The following is a description of a gene set: IL-10 or IL-6 stimulation of control 129xC57BL/6 murine bone marrow derived macrophages in the presence of LPS. We used microarrays to detail the global programme of gene expression changes in response to IL-6 or IL-10 stimulation in the presence of lipopolysaccharide. BMDMs were isolated from control, IL-6-/-, and IL-10-/- mice on a 129XBL/6 mixed background mice and differentiated in the presence of CSF-1 for 6-7 days. Cells were scraped and plated in 6 well plates at 2x10e6/well. Cells were washed with complete DMEM and rested for 1-2 hr before stimulation with combinations of IL-10 (10 ng/ml), IL-6 (2 ng/ml) or LPS (100 ng/ml) for 45 min or 180 mins. Complete biological replicates were performed. Human Gene Set: GSE5589_WT_VS_IL6_KO_LPS_AND_IL10_STIM_MACROPHAGE_180MIN_UP from publication El Kasmi KC, Holst J, Coffre M, Mielke L, de Pauw A, Lhocine N, Smith AM, Rutschman R, Kaushal D, Shen Y, Suda T, Donnelly RP, Myers MG Jr, Alexander W, Vignali DA, Watowich SS, Ernst M, Hilton DJ, Murray PJ (PMID 17114459) species: Homo sapiens Genes up-regulated in bone marrow-derived macrophages at 180 min of stimulation with IL10 and LPS: wildtype versus IL6 knockout., and this is the list of marker genes: DAZAP1, RSPO3, GTF2H4, NBEA, PPIL1, AK7, IL19, RALGDS, OSR2, TMEM98, LRRN4, IL4, PRAM1, TBRG4, PHEX, ERP44, EME1, IRS2, MIR541, TSHZ2, CDHR1, F2RL3, SLC10A2, GYS2, PTEN, RIT2, TFPT, SIN3B, TMTC2, RNASEH2A, CCDC85A, HACE1, KLF8, SLC35E3, TMEM72 (transmembrane protein 72), LRRC4C, MVP, HTR1A, SMPDL3B, MPDZ, TMEM254-AS1, LSM14B, ECHDC3, FERMT1, IGSF1, TICAM2, PACRG, FABP9, CNMD, SLC7A4, DPYSL3, MUC16, CLIC5, CYTL1, CPSF1, MAVS, TDRD5, KIFAP3 (NCBI Gene Id 22920), GABRB2, HSF5, TSHB, GSX1, NTMT2, RSPO2, ANKRD36, SPRR1B, GJA5, SHC4, ZNRF1, ZFAND4, TAS1R2, VRK3, PERP, CCR3, RAB11B, B4GALT6, PPRC1, NEFM, CHRNA6, IL1R1, PLPP3, FHL5, SLC22A1, CFAP53, FZD5, GLIS1, SAP30L, CACNA1B, PLG, FADS1, CHST7, HTR1B, TMEM158, SV2C (NCBI Gene Id 22987), S100A5, IRF2BP1, NPVF, ERCC6L, RNF128 (ring finger protein 128), STK31, ENO4, TMBIM1